Given this list of marker genes INTS15, PGM2L1, BTF3, PTEN, ARL6IP1, ANKRD11, RNF38, ATP2A2, ATP11C, TET1, ZCCHC10 (NCBI Gene Id 54819), KBTBD8, CDCA4, RAPGEF5, GNAO1, ALKBH5, GUCY1A1, KANSL1, INO80D, ATXN3, SCHIP1, CALB1, LINC02801, SLC25A24, PIP4K2A, SCAI, EVI5, STK39, MSI1, G3BP2, ELK4, ITGAV, PAIP1, PRRC1, PPM1B, ZNF148, ZFYVE28, RUFY2, MED4 (mediator complex subunit 4), PHF3, TSPAN16, TRAPPC8, CFHR5, REST, AFG2A, CNTNAP2, MEX3D, OTUD6B, HERC4, MPZL2, DCC, CXCR4, VPS13C, NRK, TPBG, PCNA, MED28, ATF7IP2, SUB1, HS3ST3A1, ARID4A, DIDO1, ATL1, HYPK, DSC2, ZNF333 (NCBI Gene Id 84449), GTF2A1, PDE10A, TOP2A, GRIA3, USP31, WDTC1, FGG (NCBI Gene Id 2266), IQCJ-SCHIP1, PURB, CFAP418, STXBP5, ZNF681, IKZF2, ADAMTS5, FOXJ3, CNTN1, OTULINL (OTU deubiquitinase with linear linkage specificity like), GABRB1, ATXN7, SPIRE1, SAMD8, CHCHD7, PEX13, PPP3R1, GTF2IRD2B, ACKR3, PCGF5, EZR, GPR85, CNEP1R1, SCML1, OSBPL8, GKAP1, HACE1, IPMK, ZBTB20, ZFAND4, ZNF264, ENTPD1, LATS1, RBFOX1, BBS5, TTPA (alpha tocopherol transfer protein), TSPAN2, TGFBR3, PTBP2, PNPLA4, LEPROT, PHF6, TAOK1, DKK3, ADGRB3, CPNE8, HACD3, ZNF275, TNRC6B, POU4F1, GABRG1, ZNF711, PTBP3, TM9SF2, N4BP2L1, ARPP19, FOXO3, PAK2, ZBTB44, ZBTB41 (NCBI Gene Id 360023), RPS6KB1, TNPO1, C1orf131, USP38 (ubiquitin specific peptidase 38), GCSAML, ALS2, GEMIN5, SELENOF, LPP, TPR, TDG, ADIPOQ, KCNC1, TTC39B, SINHCAF, CSTF3, SERINC5, TMED4, SOX9, FAM3C, ACVR2B, PHF20L1 (PHD finger protein 20 like 1), GALNT1, STAM2, SERTAD2, TMED5, CREB5, NUAK1, APELA, XRN2, MYEF2, EGFL8, B4GALT6, HECTD2, TMEM236, HNRNPUL2, RAPH1, U2SURP, NR3C2, CALM1, TAF9B, ERBIN, ADSS2, PSIP1 (NCBI Gene Id 93428), CDC14A, ADAM22, OSM, PBX2, LRRTM3, EIF1, USP33, ZDBF2, TET2, RSBN1, MYO1B, ITPRID2, TMED7, SOCS6, PIK3R1, PARP16, KLHL15, SULT1C4, NEXMIF, MEX3C, PIK3R3, GPR22, DDX3X (DEAD-box helicase 3 X-linked), MTF1, FERMT2, HERC1, NEURL3, BMPR2, KDELR3, GTF2IRD2, UQCC6 (ubiquinol-cytochrome c reductase complex assembly factor 6), CELSR1 (cadherin EGF LAG seven-pass G-type receptor 1), ZFHX4, CNBP, JAKMIP2, CENPH, ENOPH1, SPOPL, ZFHX3, WDR47, RAB31, P3R3URF-PIK3R3, CAMTA1, NEMF, SMNDC1, PHC3, SLC25A36, ATRX, ZNF569, MECP2, TXNRD1, PCLO, SV2B, PCBP2, ZFX, CUL3, ZNF260, TRMT5, ZBTB14, NSD2, FTHL17, CNTN4, PPM1D, MAP3K2, SESN3, DGKH, SGCZ, TBL1XR1, NDUFC2-KCTD14, UBR2, TP53BP1, RAD23A (RAD23 homolog A, nucleotide excision repair protein), GADD45A, SP3, ARL8B, SEC62, XPO4, RNF14, LYRM7, C3orf70, PCDH7, FAM149B1, PPP6R3, TRUB1, ACVR1C, TCF20, RPGRIP1L, MYO5A, LTBP1, PMS1, GPR63, SNRPD1, ZFPM2, ZNF229, MMP2, SLCO4C1, BEX2, ESYT2, RAB27B, SKIL, CCL28, ADH5, SDE2, AMPH, PCBP1, ADAM10, ACYP2, DYNC1LI2, TFRC, ST18, FAM76A, ONECUT2, BRWD1, PIK3CB, QKI, SMAD4, SPRED1, C4orf51, PLCH1, ZPLD1, TMEM33, ENPP2, MEF2A, PCDH11X, MCC, ANKRD55, B3GLCT, TRPM7, SERBP1, MTX3, HTR5A, ZFR, SREK1, INHBB, HLTF, VPS37A, NAV3, ABHD6, FZD3, SRSF11, MINDY2, DNAJC27, ZDHHC21, ATRNL1, SPIN4, CNOT6L, MAFB, DTD2, ZMYND19, EIF4E, NNT, RNF19A, STRBP, MSL2 (MSL complex subunit 2), COMMD3-BMI1, DMD, FLI1, DR1, PLEKHB2, BCOR, ELAVL1, CSK, DENND4C, MPHOSPH9, ZYG11B, PDS5B, NTN4, FZD4 (frizzled class receptor 4), CCAR1, BRWD3, ZNF280C, CEP85L, PLPPR1, PCBP4, OTX2, CTTNBP2, CAVIN4, NEK7, FBXW7, HAPLN1, VMA21, MAP4, EHMT1, PDE7B, GFRA1, KIF2A, CCNYL1, GABPB1, SLC1A3, PTPN12 (protein tyrosine phosphatase non-receptor type 12), MOB1B, ZNF713, ZC3H12C, MIER3 (NCBI Gene Id 166968), MACF1, ARK2N, IFT81, CHST14, DDHD1, COX15, USP48, PABPC5, NHLRC2, ATF2, NUDT12, PIK3CG, SOWAHC, MTPAP, OPRM1 (opioid receptor mu 1), SRCIN1, ANGEL2, PI4KB, TMEM169, CDC42BPB, FTO, ETNK1, ZNF658, UGT3A1 (UDP glycosyltransferase family 3 member A1), ARHGAP21, PIAS1, ZNF484, TEAD1, RNF168, SMAD5, TMEM245, KAZN, RGS3, MFAP3L, FBXO22, ATXN1, TRAPPC1, GEMIN2, PLAGL1, TSTD2, ZEB1, TLNRD1, RNF207, RAB22A, GPR137B, PAG1, SYNDIG1L, TRMT10A, B3GAT1, RNPS1, MMAB, TENT4B, PIGN, ZNF91, WAPL, EDEM3, WDR17, IKBIP, SLC4A4, EPC1, TNRC18, CDK6, DSG2, TOP2B, KMT2D, KLF9, PHIP, UTP23, THUMPD1, SLC2A13, SLC6A11, RPP30, TP53INP1, LUC7L2, ADPRH, RAD51AP1, SGIP1, FNIP2, CPNE3, EBF2, UGGT1, MAP7, CXXC4, NF1, VEZT, IREB2, TAB2, ZNF281, ARHGAP6, CDK13, ADAMTSL3, KANSL1L, CLASP2, BOLL, WASHC3, SLC26A4, CSDE1, CCDC186, GPAM, RNF2 (ring finger protein 2), WASF1, KLHL28, GNB2, SPINK7, GPC4, PAPOLA, TBP, NFAT5, VASP, JAKMIP3, PCGF3, UBE2G1, SLC44A5 (NCBI Gene Id 204962), GNS, CD47, here is a description of the gene set: species: Homo sapiens Human Gene Set: MIR548A_3P from publication Chen Y, Wang X (PMID 31504780) Genes predicted to be targets of miRBase v22 microRNA hsa-miR-548a-3p in miRDB v6.0 with MirTarget v4 prediction scores > 80 (high confidence targets).